The following is a description of a gene set: Serial comparison between Th1 and Th17 tumor-specific cells cultured in vitro and ex vivo after transferred into sublethaly irradiated B6.PL mice. Th17-derived cells acquire Th1-like properties in vivo but maintain a distinct molecular profile. species: Homo sapiens Human Gene Set: GSE26030_UNSTIM_VS_RESTIM_TH17_DAY5_POST_POLARIZATION_UP Genes up-regulated in Th17 cells 5 days post polarization: control versus stimulated with anti-CD3 and anti-CD28. from publication Muranski P, Borman ZA, Kerkar SP, Klebanoff CA, Ji Y, Sanchez-Perez L, Sukumar M, Reger RN, Yu Z, Kern SJ, Roychoudhuri R, Ferreyra GA, Shen W, Durum SK, Feigenbaum L, Palmer DC, Antony PA, Chan CC, Laurence A, Danner RL, Gattinoni L, Restifo NP (PMID 22177921), and this is the list of marker genes: SQOR, DOK6, GSTT2, DNMT3B, MAGEE1, TTL, TRIM8, ABTB3, NME3, CKB, PFDN5, CCDC125, ETV6, ARNT2, SLAMF1, CD44, TCEA2, ABHD4, NMB, MTM1, PPP1R12C, PLEKHO1, DNAJA4, PRDM5, ENTPD6, PLK3, PDE4B, IL27RA, PEPD (peptidase D), RASGRP1 (RAS guanyl releasing protein 1), AR, TSPAN2, CARMIL2, MOCOS, CUL9, SMPDL3A, FHL3, EHHADH, MITF, LDAF1, ENPP5, CASTOR1, CTSA, MAF, NPEPL1, MOGS, GALNT7, SNORA61, ACAD8, UQCC3, CMTM3, PON3, RRAD, SLC39A6, PARP14, MVP, FAM120A, BRD2, TBC1D14, GPR18, CMPK2, RILPL1, E2F6, HSPBP1, CHST12, POU2F2 (NCBI Gene Id 5452), CDYL2, PSEN2, CASD1, NUMA1, AKAP13, PRDX2, PTPN3, PARP12 (NCBI Gene Id 64761), NFKB1, SMYD2, HEXA, DLG5, IL17RE, CYTIP, RASD2, PUSL1 (NCBI Gene Id 126789), CELSR1, RAB6B, GRAP, HIVEP3, QSER1, BCL11B, CRLF3, ABHD11, TMEM185B, KCNIP2, SELENON, PPT2, GPR132, ANK1, CTXN1, CD53, PTGER4, PRKCQ, C1QTNF12 (NCBI Gene Id 388581), OSTF1, ABCC3 (ATP binding cassette subfamily C member 3), CAMK2B, RMDN2, SRPK1, VARS2, ZNFX1, GM2A, GABBR1 (NCBI Gene Id 2550), TNFRSF4, TBL1XR1, SPINT2, EID2, SREBF2, NSD1 (nuclear receptor binding SET domain protein 1), RNF122, ARHGEF18, SLC44A2, UNC93B1, WDR83, TNRC6A, KIAA1328, VPS54, ETNK1, XKR8, NAPB, GNG10, NUDT22, LRBA, PLXDC2, EBI3, PRSS35 (NCBI Gene Id 167681), KIF2A, VAMP8, GALM, XDH, GTPBP10, GYPC, ASB2, MCUR1, NOTCH2, GPD1L, TEX2, MACROD1, EML3, RPS6KA1, THY1, AGO1, FAM117A, ST3GAL3, UTP11, MIR31, FBXO27, DNAI4, PLAC8, CMTM4, SH3BGRL3, NR2C1, ECI1, MLH3, BSCL2 (NCBI Gene Id 84753), SCAMP3, CEP170B, IL5, SLC1A5, COTL1, ASAH2, RINL, PLCL2, ISG20, B3GALT2, PGLYRP1, SMAD1, LDB1, CDC42SE1, GFI1, INSR (NCBI Gene Id 3643), ARAP2, NRIP1 (NCBI Gene Id 8204), LCP2 (NCBI Gene Id 3937)